Given this list of marker genes Fgf22, Kl, Fgf8 (NCBI Gene Id 14179), Fgf23, Fgf1, Fgf4, Fgfr1, Fgf17, Gipc1 (GIPC PDZ domain containing family, member 1), Fgf20, Fgf5, Fgf6, Fgf10, Fgf2, here is a description of the gene set: Reactome Pathway: FGFR1 ligand binding and activation This event has been computationally inferred from an event that has been demonstrated in another species.<p>The inference is based on the homology mapping from PANTHER. Briefly, reactions for which all involved PhysicalEntities (in input, output and catalyst) have a mapped orthologue/paralogue (for complexes at least 75% of components must have a mapping) are inferred to the other species. electronically inferred by orthology from the curated human pathway studied in species Mus musculus part of: Signaling by FGFR1